The following is a description of a gene set: Mouse Gene Set: GOCC_CATALYTIC_COMPLEX species: Mus musculus A protein complex which is capable of catalytic activity., and this is the list of marker genes: Med27 (mediator complex subunit 27), Prps2, Ndufb7, Klhl13, Klhl29, Ppp1r15a, Lage3, Map3k7, Eif4a3l2, Psma6, Fbxo27, Mettl3, Cks1b, Tbp, Abtb1, Riok1, Sin3b, Smarca2, Nus1 (NCBI Gene Id 80282), Crnkl1, Prpsap2, Mettl14, Mat2a, Itch (itchy, E3 ubiquitin protein ligase), Ecpas, Hdac2, Gtf2a2, Msl2, Cul2, Trp53rka, Tuft1, Klhl3, Rad23a, Dgcr8, Klhl5, Ilvbl, Ncstn, Dbf4, Cyb5b, Uqcrb, Psmc5, Rnf2, Dnai3, Max, Pramel7, Pole2, Psen2, Uqcrh, Gtf2a1l, Bcas2, Dact1, Iars1, Ndufs1, Sucla2, Gng13, E2f6, Gtf2a1, Casp8, Fbxo44, Gng11, Pomt1, Asb17, Ppp1r3a, Keap1, Setd1a, Gpr37, Fbxl13, Snrpe, Naa12, Fbxl3, Men1, Fbxo2, Anapc1, Hadhb, Prpf31, Dnal1, Elp4 (elongator acetyltransferase complex subunit 4), Uqcc3, Aebp2, Ube3d, Sap30l, Hdac3, Pigu, Hnrnpa2b1, Pggt1b, Cdc27, Med31, Bcor, Eprs1, Amn1, Atp6v1b1, Pfkfb1, Cks1brt, Ube2d1, Psma7, Fbxo31, Atxn7, Suz12, Gnao1, Atg14, Pik3cg, Mccc2, Rcor2, Atp6ap2 (ATPase, H+ transporting, lysosomal accessory protein 2), Zcchc8, Psenen, Kmt2d, Psme1, Gng3, Dync1li2, Uqcrc2, Med1, Meaf6, Usp22 (ubiquitin specific peptidase 22), Rpp25l, Ndufs3, Sptlc2, Vhl, Cul1, Psmd1, Gnas, Klhdc2, mt-Nd1 (NCBI Gene Id 78300), Cox8c, Pik3cb, Coq5, Snrpf, Insrr, Ndufa8, Tada3, Cdkn1a, Hint1, Sinhcaf, Pole4, Dynlt1f, Taf12, Hnrnpu, Alyreffm1, Dkc1, Polr3d, Trmt61a, Mat1a, Hpse, Ppp3r2, Wdr93, Rsf1, Gsk3a, Rere, Med23, Dynlt4, Ankrd9, Socs7, Rb1, Mta2, Gnai3, Ccng2, Rmi2, Atp5pf, Dcaf10, Ikbkb, Ndufb3, Taf10, Fadd, Uqcr11, Atp6v0c, Spcs3, Grhpr, Taf9 (NCBI Gene Id 72718), Ccna2, Nrip1, Hnrnph1, Atp6v0a4, Pigk (phosphatidylinositol glycan anchor biosynthesis, class K), Med13, Gtf2f2, Casc3, Wdr5, Cdk2ap1, Rragc (Ras-related GTP binding C), Ganab, Dcaf13, Brca1, Eny2, Nudcd3, Pigyl, Ppp1r3c, Zswim8, Atg12, Txnl1, Cdk9, Rbbp4, Shoc2 (NCBI Gene Id 56392), Kctd13, Alyref, Setd1b, Atp6v1g3, Fbxl6, Tmed10, Akap5, Snrpg, Cwc27, Pramel59, Aph1c, Exosc6, Hsd17b10, Eno2, Psmd7, Pramel28, Mta1, Nhej1, Nsmce2, Ccng1, Ndufs5 (NCBI Gene Id 595136), Psmb6, Uba2, Tep1, Prpf8, Elp6, Dhx38, Sart1, Gid4, Spsb3, Mga, Dydc1 (DPY30 domain containing 1), Apc2, Hdac6, Fzr1, Ercc2, Crbn, Ccnq, Pigv, Gatad2a (NCBI Gene Id 97459), Tex16, Rnf7, Phkg2, Lsm3, Cdc5lrt10, Rpl5, Polr1d, Cox5b, Baz1a, Nsmce1, Cnep1r1, Pias4, Psmb10, Pparg, Cox15, Eid3, Cdc5lrt1, Kmt2b, Polr2k, Ipp, Camk2d, Prkci, Gna12, Wdr77, Pramel30, Ss18l1, Hnrnpf, Fbxo24, Axin1, Polr2j, Ccne1, Ppp1r3g, Cwc22rt2, Polr1b (polymerase (RNA) I polypeptide B), Ube4b, Camk2b, Pigp, Atp5mk, Nfs1, Dhx9, Prorp, Tbc1d5, Dcun1d3, Prdm8, Ndufb5 (NADH:ubiquinone oxidoreductase subunit B5), Atp5f1e, Ppp2r5e, Mat2b, Socs2, Ticam1, Golga7, Nsmce3, Taf11, Ccny, Gna13, Farsb, Dyrk2, Brd7, Rnaseh2b, Pik3c3, Naa20, Ccnb1, Zfand2b (zinc finger, AN1 type domain 2B), Hnrnpr, Hspb1, Chm, Decr1, Ppp1r3f, Wdr83, Magt1, Ndufa5, Prkar1b, Fbxo25, Klhl11, Tarbp2, Cdk5r2, Ubqln4, Atp6v1e1, Psma8, Traf7, Gan, Ppp2r2c, Dnajb2, Eloc, Klhl1, Cfh, Naa15, Mib2, Cox8b, Cks2, Ppil2 (NCBI Gene Id 66053), Cyba, Oog1, Pik3r1, Gtf2e2, Pramel55, Pcmtd1, Atp5me, Ppp1ca, Glmn, Dnah14, Pole, Ndufb2, Ndufb8, Dcaf15, Tcirg1, Klhl23, Hmgxb4, Uty, Cox6a2, Wrap53, Ndufs8, Mtarc1, Piga, Pdhx, Ppp4r2, Msl1, Polr3gl, Rbmx, Ceacam2, Srsf1, Polr1a (NCBI Gene Id 73088), Actl6b, Ppp1r3b, Cfap70, Polr3e, Ccne2, Taf9b, Pcna, Hr (lysine demethylase and nuclear receptor corepressor), Nme8, Ube2j2, Clpx, Pramel40, Pfkl, Mrps36, Mnat1, Atp5pb, Uqcrfs1, Prpsap1, Gucy1b2 (guanylate cyclase 1, soluble, beta 2), Uchl5, Cdc5lrt7, Arid1b, Ctag2, Rnf217, Gcsh, Gpaa1, Nox4, Hsd17b12, Dnah8, Cdc5lrt4, Epop, Jade2, Ppp2r1a (NCBI Gene Id 76182), Psmf1, Arih1, Paf1, Gnb1, Dcaf17, Sptssa, Prpf4b (pre-mRNA processing factor 4B), Nolc1, Hcfc2, Supt3, Ctag2l2, Dynlt5, Mras, Fbxl15, Sem1, Dcaf7, C1d, Anapc16, Psmb3, Polr2l (NCBI Gene Id 66491), Fem1a, Cul5 (NCBI Gene Id 78529), Supt20, Qars1, Ash2l, Dpf3, Ino80e, Sharpin, Polr2a, Zswim5, Eif4a3, Ikbkg, Dctn4, Tsen2, Gnat2, Camk2g, Ppp2cb, Prkag3, Gsk3b, Taf4, Asb12 (ankyrin repeat and SOCS box-containing 12), Ezh1, Fbxl18, Klhl38, Usp14, Syf2, Klhdc10, Pidd1, Ramacl, Tmem258, Hdac11, 9630013A20Rik, A1cf, Pola2, Fcnb, Gclm, Iscu, Taf6l, Ing4, Gmpr, Pramel48, Kansl2, Dynll2, Ccnc, Psme2, Gar1, Psmd6, Rpp30, Ugt3a1, Atg5, Traf2, Sf3b3, Gucy1a2, Pik3r6, Xab2, Pik3cd, Anapc5, Exosc3, Pramel36, Phc2, Thbd, Bard1, Fbxw7, Sptlc3, Brms1, Rbx1, Pramel21, Snrpa1, Cdk4, Neu2, Dnmt3b, Virma, Ss18, Dlst, Ndufb11, Clpp, Ddx21 (NCBI Gene Id 56200), Nhp2, Prickle1, Gtf2h4, Psmd14, Zfp541, Cwc22rt5, Rmi1, Pold3, Asb2, Cdk3, Gnb4, Psmc4, Rac2, Dnah5, Fntb, Mecom, Hdac10, Rbmxl1, Pan2, Ormdl3, Klhl4, Ndufaf2, Fam98b, Mettl1, Dynlt2a1, Trerf1, Ctu1, Trim40, Rnaseh2a, Rcor1 (REST corepressor 1), Ogdh, Alyreffm4, Carhsp1, Erc1, Atp6-ps, Hcfc1, Rpp40, Ago1, Hras, Plaur, Med11, Klhl41, Cxxc1 (NCBI Gene Id 76064), Afg3l1, Ppie, Slc10a2, Cyc1, Trim21, Dnai2, Exosc8, mt-Co1, Ncf2, Arid4b, Alyreffm6, Gng7, Ube2srt, Crcp, Snrpert, Ramac, Gng2, Brd8, Ndufab1, Brd8dc, Ino80b, Ambra1, Ube3a, Samd7, Oog3, Ulk1, Polr2m, Uqcr10, Gpihbp1, Med17, Phf20, Ptges3, Ndufa7, Cdk11b (cyclin dependent kinase 11B), Ndufa9, Plod1, Med7, Gna14, Psmd9, Ppp2ca, Ndufa4l2, Smg7, Ddx41 (NCBI Gene Id 72935), Atp6v0b, Snx4, Rnasek, Dmac1, Trrap, Gng12, Exosc4, Pop5, Rbck1, Vps4b, Cbx2, Klhl15, Rad51c, Chuk, Depdc5, Rtf1, Prkdc, Taf3, Htra2, Cradd, Atp5f1c, Gm13040, Ndufv1, Pramel33 (PRAME like 33), Atg16l1, Psma1, Ppp2r3d (NCBI Gene Id 626662), Gng5, Asb11, Rad51, Prkaa2 (NCBI Gene Id 66516), Sgf29, Kat5, Yy1, Gtf2h3, Med12, Fam8a1, Phf19, Dnah10, Ranbp2, Ndufa13, Ascc2, Phf20l1, Top2a, Pramel18, Ppp1r12a, Ndufa11, Nvl, Prdm4, Fanci, Rtcb, Gng8, Ceacam1, Pramel14 (PRAME like 14), Capn2, Cdc40, Suds3, Stk11, Mtor, Trex1, Gnb5, Polr2f, Maea, C9orf72, Znfx1, Dhx8 (NCBI Gene Id 217207), Naa30, Rraga, Trp53rkb, Qprt, Dync2i1, Ercc8, Pramel56, Ercc3, Pramel60, Gng4, Zfp36, Lig4, Amt, Nat10, Trim37, Dync2li1, Cdk14, Ccdc115, Dcun1d2, Psmb7, Klhl18, Taf6 (TATA-box binding protein associated factor 6), Fam98c, Xrcc6, Immp1l, Fbxw11, Hdac4, Klhl9, Ppp1cb, Pcgf5, Prkag1, Phc3, Ppp2r5a, F3, Rpn2, Pex2, Krtcap2, Cab39, Cdkn2d, Brcc3, Atp6v1f, Rev3l, Smarcd3, Coq6, Kansl1, Actr5, Topors, Rpp38, Dynlrb1, Ogt, Prps1l3, Pbrm1, Ctdnep1, Ndufb11b, Gatb, Rangap1, Fbxl20, Dad1, Dynlrb2, Bud31, Smc6, Fbh1, Bptf, Dnah3, Atp6v0d1, Odad1, Ccdc103, Bcl11a, Gngt2 (NCBI Gene Id 14710), Pelp1, Kctd2, Xrcc5, Polr3k, Prkx, Dhx35, Abat, Capns1, Hmga1, Dnah2, Sesn2, Bcl11b, Gtf2b, Pafah1b3, Gpatch1, Zfp335, Med10, Ep400, Megf8, Supt7l, Naa11, Zzz3, Brms1l, Pramel61, Exosc5, Mlst8, Hsd17b8, Adrm1, Tmem199, Prkaa1, Actl6a, Jade1, Rad18, Gnaz, Ring1, Mbtd1, Actr8, Pold4, Rpn1, Pramel11, Cflar, Ccnt2, Stub1, Rnmt, Cwc22, Elp1, Hnrnpa1, Fxn, Cwc22rt7, Plaa, Brpf1, mt-Nd4l, Zswim4, Chd3, Atp6v1c2, Dnah11, Anapc7, Ndufab1-ps, Noxo1, Pramel23, Wdr18, Anapc2, Atp5f1a (ATP synthase F1 subunit alpha), Lyrm4, Sec11c, Rb1cc1, Cox7b, Ascc1, Tex24, Pccb, Sap130 (Sin3A associated protein), Cox7c, Syvn1, Polr2h, Smarca4, Cox6a1, Babam2, Pafah1b2, Pmpcb, Pramel17, Cdk10, Mir28a, Cox10, Ccdc65, Asb4, Rnf144a, Anp32e, Cul3, Dnah7c, Klhl22, Cdk16 (NCBI Gene Id 18555), Tada1, Fbxl4, Hdac9, Pola1, Spsb4, Primpol, Pramel35, Ndufs4, Mus81, Ctnnbip1, Suclg1, Las1l, Anapc10, Phkg1, Jade3, Trmt112, Kdm1a, Gtf2h5, Psmb2, Atp6v1h, Ppp4r3c1, Cwc22rt1, Acte1, Polr1g, Fbxo8, Yeats4, Gtpbp1 (NCBI Gene Id 97981), Nccrp1, Rpap1, Phka2, Cdkn1b, Tsn, Gatc, Kbtbd2, Taf13, Cox7a2, Elp3, Elp2, Pard3, Ranbp9, Klhl25, Med18, Ube2n, Gnai1, Ndufs7, Bicra, Dapk1, Fem1al, Psmd8, 0610010K14Rik, Gclc, Ppp3cc, Tprkb, Suclg2, Tbl1xr1, Gnat3, Mlec (malectin), Immp2l, Smarcc1, Msl3l2, Fem1b, Uqcrh-ps1, Acvr2b, Mars1, Kars1, Ccin, Fbxo3 (NCBI Gene Id 98847), Rbm8a2, Arid2, Atp6v1c1, Aph1a, Klhl42, Rbm15b, Rfc4, Kbtbd6, Snrpd2, Dpm1, Pramel19, Pold2, Uqcrq, Kmt2a, Dclre1c, Ndufb4c, Elp5, Polr2c, Atp6v1g1, Baz1b, Hdac5, Scly, Dnttip1, Slx4, Oog4, F7, Phf1, Pramel51, Plrg1, Dcun1d5, Lig3 (NCBI Gene Id 28083), Magohb, Psmd5, Fbxo48, Aph1b, Dda1, Ivns1abp, Cox7a2l, Hnrnpc, Stt3a, Rnf11, Cdc20b, Prkab1, Qtrt1, Fbxl14, Dpy30, Ddost, U2af1 (U2 small nuclear ribonucleoprotein auxiliary factor (U2AF) 1), Evx1os, Naa10, Pik3ca, Eme2, Mbd3, Cox7b2, Naa25, Actg1, Phc1 (NCBI Gene Id 13619), Kansl3, Arid4a, Kmt2e, Psmd13, Rbbp5, Cox5a (NCBI Gene Id 12858), Tnfaip1, Rars1, Cbx8, Yeats2, Plau, Polr3a, Ubqln1, Fbxo17, Magoh, Spcs1, Otulin, Rnf168, Frg1 (FSHD region gene 1), Klhl40, Zyg11a, Acvr2a, Pramel22, Rag1, Atg101, Pabpc1, Ccnf (NCBI Gene Id 12449), Adrm1b, Raly, Ube2s, Srrm2, Cat, Atg13, Dph2, Pramel39-ps, Ndufv3, Ndufs6, Akap14, Abhd11, Ezh2, Strada, Alyreffm9, Rabggtb, Bmi1, Elovl6, Casp2, Klhl10, Anapc11, Actr6, Arxes2, Ago2, Bcl7c, Ube2v2, Ptpa, Siah1a, Brpf3, Nedd4, Acvr1b, Dcaf8, Arxes1, Alyreffm3, Ndufb6, Sin3a, Dnai4, Pard6a, Cox4i1, Ndufb4b, Tbl1x, Ube2e1, Smurf2, Atp5po, Tet1, Pik3r2, Naa50, Ndufa6, Actbl2, Snw1, Med6, Rictor, Trim63, Snrpd3, Cand1, Cox6b1, Foxred1, Dcaf6, Sptlc1, Ube2b, Fbxo15, Atp5mc3, Sae1, Neurl2, Gng14, Calm2 (NCBI Gene Id 75700), P4hb, Mgrn1, Ndufa2, Tcea1, Wdr4, Gm6993, Morf4l1, Sf3a1, Pigt, Tsen54, Cdc20, Cox6c, Fem1c, Mbl2 (NCBI Gene Id 17195), Dmac2, Taf1, Rnf40, Dynlt3, Klhdc3, Coq9, Ccnj, Taf4b, Rpp14, Supv3l1, Fbxl5, Tgfbr2 (transforming growth factor, beta receptor II), Cul4a, Psmb8, Trmt10c, Dars1, Dnah6, Gmpr2, Dctn2, Cdk5r1, Ormdl1, Ube2d2a, Atad5, Ldhb, Chd5, Pycard, Dtl, AI597479, Ppp4r3b, Rcor3, Pramel25, Tmem183a, Cwc15, Uqcrc1, Cdc5lrt8, Polg, Snrpb, Rbm8a, Lsm7, Acd, Btrc, Kdm3a, Rad23b, Thumpd2, Polr2b, Bcl7a, Polr3h, Psmd10, Klhl6, Pramel13, Gatad2b, Prim1, Sall1, Dnah9, Polr2i, Dnmt3l, Ccnl2, Ormdl2, Fbxw8, Dnai1, Fbxl19, Ide, Dynll1, Cul4b, Xrcc4, Sel1l, Cfdp1, Sdhc, Disc1, Nscme3l, Mideas, Rmnd5a, Sf3b2, Cdc16, Cbx5, Hadha, Tgfbr1, Taf2, Idh3a, Psme3, Dek, Tox4, Fbxo6, Skic8 (NCBI Gene Id 93803), Erhrt-ps, Eftud2, Smcr8, Lrrc75a, Gnai2, Fbxl9, Sf3a2, Atp5mc2, Mkln1, Eno4, Acvr1c, Brcc3dc (BRCA1/BRCA2-containing complex, subunit 3, domain containing), Ctag2l1, Dmap1, Insr, Spop, Pigh, Cyren, Coq7, Sf3b1 (NCBI Gene Id 98194), Aimp2, Fnta, Psmd3, Prps1, Daw1, Pramel44, Ppp2r1b, Dync2i2, Prkn, Arih2, Map3k5, Helq, Smc5 (structural maintenance of chromosomes 5), Atp6v0a2, Nck1, Kbtbd8, Ppp1r3d, Pigm, Mapkap1, Ppp2r5b, Actb, Prkar1a, Anapc15, Papss1, Rrm1, Polr1c, Pef1, Gon7, Pigq, Dcaf12l2, Kat6a, Itpr1, Setd5, Dhdds (NCBI Gene Id 97199), Wdfy3, Duox2, Alg14, Pdss2, Ddx23, Lsm2, mt-Atp6, Pramel49, Ccni, Ube2i, Ripk1, Naa16, Dcun1d1, Spopl (NCBI Gene Id 99466), Atp5mj, Cdc73, Thg1l, Pagr1a, Uxs1, Ppp2r3a, Gnmt, Cbr4, Sdhb, Ing1, Rpp21, Vps72 (vacuolar protein sorting 72), Nop10, Pramel46, Rmnd5b, Ruvbl1, Pramel34, Anapc13, Klhdc1, Dnai7, Cwc22rt3, Smarcc2, Irs1, Ascc3, Kat2a, Bckdk, Med20, Pan3, Kat14, Taf8, Trmt6, Ccnd3, Zswim6, Chd4, Atp6v0a1, Fam98a, Sdha, Psme4, Hexb, Spg7, Blm, Polrmt, Acacb, Baz2a, mt-Nd5, Ncf4, Dnah12, Atp5f1b, Gnat1, Ino80, Dynlt2b, Rragd, Idh3g, Polr3g, Aurkaip1, Fancd2, Csnk1a1, Pcca, Dnah1, Rbm47, Ago4, Pramel32, Fbxl7, Anapc4 (NCBI Gene Id 67924), Psmd4, Ddx5 (NCBI Gene Id 72118), Amfr, Atp6v0d2, Cdc26, P3h3, Ndufa12, Dnhd1, Ccnd2, Idh3b, Ier5, Ppp2r2b, Hnrnpab, Stt3b, Qtrt2, Dnah7a, Ddx1, Atp6v1a, Wdr74, Pop1, Psmb11, Drosha, Cyb5r3, Pramel50, Cybb, Ubr2, Rbx1-ps, mt-Cytb, Prim2, Luzp1, Taf5l, Palb2, Atp6ap1, Wtap, Rrm2b, Dld, Axin2, Klhl17, Klhl24, Dynlt1b, Farsa, Dync1i1 (NCBI Gene Id 209813), Pramel37, Pramel53, Sf3a3, Dlat, Elob, Fbxo4, mt-Co2, Psmc6, Gng10, Cbx4, Ubr1 (NCBI Gene Id 99008), Duox1, Zdhhc9, Ostc, Cdc23, Hdac1, Hnrnpm, Ncf1, Rbbp7, Hdac7, Ube2v1 (NCBI Gene Id 66589), Satb2, Gnb2, Eme1, Eed, Ing2, Pdcd6, Samd11, Prkaca (protein kinase, cAMP dependent, catalytic, alpha), Hoxb5os, Gna11, Dcaf4, Dpm2, Rbm22 (NCBI Gene Id 66810), Sdhd, Ppp1cc, Nox3, Cwc25, Brd4, Kbtbd3, Alyreffm8, Wdr41, Kctd5, Mccc1, Myo1c, Calm3, Lztr1, Pklr, Kdm6a, Chrac1, Cdc5l, Ercc6, Aimp1, Psmb5, Brd1, Gucy1b1, Ing5, Dcaf12, Psmb9, Rtraf, Tusc3, Pigs, Dph1, Pik3r4, Rpp25, Tsnax, Psma5, Rbm15, Capn1, Kmt2c (lysine (K)-specific methyltransferase 2C), Srcap, Cdc5lrt6, Clp1, Cblc, Klhl20, Coq4, Bcl7b, Bckdhb, Chml, Skp2, Phkb, Chaer1, Ccnb2, Dync1h1, Gldc, Psmd12, Pcgf6, Pramel57, Rbm44, Polr3c, Rchy1, Atf2, Casp9, Lars1, Psma2, Pdha2, Afg3l2, Rnf14, Psma3, Atp6v0e, Csnk2b, Bccip (BRCA2 and CDKN1A interacting protein), Sap18, Pramel6, Csnk2a1, Rnf19b, Prmt1, Ube2a, Becn2, Mad2l2, Ppwd1, Ppp4r3a, Ppp2r5c, Asb1, Klhl7, Pik3r5, Cul9, Pramel16, Ccnt1, Pramel31, Polr1f, Mtrex, Dis3, Alyref2, Atp5pd, Lpl, Prkra (NCBI Gene Id 99272), Vps4a, Psmb1, Ccnd1, Slu7, Klhl30, Ndufc2, Cop1, Ypel5, Arid1a, Ext2, Mcrs1, Dctn1, Eno3, Med21, Vcp, Atp6ap1l, Alyreffm10, Rnf144b, Trmt11, Alyreffm11, Atg5lrt, Ndufb9, Ndufc1, Cdk13, Katna1, Zbtb8os, Psmc3, Dcun1d4, Snrpd1, Epc2, Cdk2ap2, Cox6b2, Exosc2, Prmt5, Atg3, Sf3b5, Pcgf2, Cdk7, Top3a (NCBI Gene Id 21975), Ing3, Gnptg, Rnf20, Siah1b, Sec11a (SEC11 homolog A, signal peptidase complex subunit), Pyurf, Kdm3b, Cdk5, Brca2, Paxx, Zc3h13, Cdk12, mt-Co3, Atp5mc1, Alyreffm7, Crebbp, Polr2d, Pik3r3, Dcaf1, Nsmce4a, Elobl, Taf7, Cwc22rt6, Ext1, Ppcdc, Pramel41, Fbxl22, Prkacb, Mybbp1a, Ppil1, Ndufa11b, Kbtbd7, Polr3b (polymerase (RNA) III (DNA directed) polypeptide B), Pramex1, Kat6b, Mir27a, Nox1, Ugt3a2, Prpf19, Dhtkd1, Pop7, Prpf6, Kat7, Fbxw4, N6amt1, Mbd2, Trpc4ap, Alg13, Gid8, Smg6, Pramel20, Commd1, Ndufa10, Vac14, Ccnb1-ps, Ccnjl, Prkar2a, Zfand2a, Csnk2a2, Cox6c2, Pkm, Tert, Rrm2, Ppp2r2d, Pramel29, Acvr1, Dbt, Morf4l2, Fbxo32, Ess2, Srrm1, Cactin, Pramel26, Pfkm, Pramel27, Bod1, Dnali1, Ppp2r5d, Ncoa6, Rnf19a, Ctnnb1, Dnah17, Asb9, Gnaq, mt-Nd4, Tfpt, Psen1 (NCBI Gene Id 19164), Ppil3, Atxn7l3, Kctd17, Fbxo39, Spcs2, Mta3, Psmc1, Igf1r, Atp5mf, Rnf8, Dnal4, P3h4, Ppp2r2a, Polr3f, Pdk1, Spaar, Brap, Ncor1, Hnrnpk, Klhl35, Ppp3cb, Dync1li1, Spsb2, Med30, Cecr2, Spsb1, Dna2, Armc8, Dynlt1a, Prkab2, Ddb1, Ncor2, Ppp4r4, Psmd2, Tsen34, Phf10, Bicral, Nkd1, Ppp3r1, Dicer1, Kat8, Bckdha, Uvrag, Smarcb1, Senp3, Ube2c, Pramel47, Exosc9, Gon4l, Fbxw5, Atg16l2, Gtf2f1, Pramel12, BC048507 (cDNA sequence BC048507), Zyg11b, Stradb, Nrbf2, Cox8a, Fbxl17, Apobec1, Dnmt3a, Gtf2h2, Camk2a, Klhl2, Sirt1 (NCBI Gene Id 93759), Klhl8, mt-Nd2, Gnb3, Rabggta, Kbtbd12, Cdk1, Aqr, Cdc5lrt9, Dync2h1, Rnaseh2c, Ino80d, Dcaf12l1, Paxip1, Alyreffm5, Gnal, Ndufb4, Polr1h, Ogdhl, Snrpb2, Cacybp, Drc1, Cdk2ap1rt, Atm (NCBI Gene Id 77416), Atp5mg, Golga7b, Exosc10, Ost4, Mtf2, Kat2b, Gmppb, Psmd11, P4ha2, Rfc1, Pcgf1, Prkcsh, Fbxl12, Msl3, Dpf2, Pramel43, Nsd1, Taf5, Ndufs6b, Yju2, Hexa, Dcaf11, Cfhr4, Jmjd1c, Ccna1, Pdha1, Dis3l, Appbp2, Ankib1, Smarce1, Ndufv2, Sos1, Usp25, Zfp217, Med24, Trp53bp1, Ldha, Taf7l, Cdk6, Kctd10, Mrgbp, Dpm3, Cbx6, Phf12, Dnah7b, Cdk2, Rnf7l, Ccno (cyclin O), Brd9, Apc, Det1, Phf21a, Myzap, Psmb4, Gtf2e1, Prkag2, Eno1b, Erh (ERH mRNA splicing and mitosis factor), Atp6v0e2, mt-Nd3 (NCBI Gene Id 17718), Gucy1a1, Polr1e, Ccnk (cyclin K), Wdr26, Snrnp40, Tbpl1, Cnppd1, Mocs2, Pramel54, Fbxo42, Ubr3, Ppp1ccb, Pold1, Wdtc1, Cox4i2, Klhl28, Jarid2, Zer1, Ubac1, Pramel5, Wdr5b, Tes3-ps (testis derived transcript 3, pseudogene), Sap30, Naa38, Hnrnpa3, Dcaf8l, Eno1, Pigc, Syncrip, Naa35, Chd8, Cul7, Atp5f1d, Ino80c, Usp47, Fap, Ube4a, Ugt1a1, Smg5, Gngt1, Mphosph6, Gna15, Rragb, Cdc5lrt5, Pramel15, Polg2, Dynlt1c, Ndufa1, Dync1i2, Ppp4r3c2, AA467197, Oog2, Leo1, Pole3, Atp6v1g2, Qrsl1, Gtf2h1, Klhl12, Pfkp, Wdr82, Tada2b, Snrnp200, Kansl1l, Anapc15-ps, Dcaf5, Fbxl2, Ranbp10, Osgep, Ccnh, Pdhb, Tfip11, Zfc3h1, Noxa1, Becn1, Pramel1, Cwc22rt4, Ep300, Tex10, Gnl3l, Pnkp, Exosc7 (NCBI Gene Id 66446), Klhl21, Ndufa4, Ccnb3, Camk1g, Ddb2, Pdk2, Ndufb10, Capns2, Cox7a1, Dmac2l, Fbxl21, Enc1, Dr1, Ago3 (argonaute RISC catalytic subunit 3), Smarcd1, Prkar2b, Calm1, Pafah1b1, Pop4, Isy1, Coq3, Pnn, Phka1, Fbxl16, Ctr9, Ppp1r10, Polr2e, Ppp3ca, Tmed10-ps, Pdss1, Pcgf3, Ndufb1, Ppp4c, Rnf31, Fbxo7, Pramel45, Smarcd2, Eif4a3l1, Gmppa, Tada2a, Cbll1, Eef1e1, Bod1l, Gng5c, Clns1a, Nek10, Polr2g, Fbxo9, Zbtb7a, Tpr, Pramel24, Smarca5, Atp6v1d, Sptssb, Pramel42, Nfrkb, Znhit1, Ptges3-ps, Pramel38, Psmc2, Ndufs2, Kdm6b, Ruvbl2, Atp6v1b2 (NCBI Gene Id 97492), Dpf1, Ndufa3, Epc1, Skp1, Hdac8, P4ha1, Prps1l1, mt-Nd6, Ppp1r3e, mt-Atp8, Exosc1 (NCBI Gene Id 67682), Pnpt1, Cbx7, Cdk8, Lsm11 (NCBI Gene Id 72290), Ccnl1, Fbxo45, Ppp1r15b, Smarca1, Mbip, Snrpn, Psma4